Given this list of marker genes NEK3, PRORP, FANCF, STUB1, GSTM4, PFAS, ITPRIPL2, RCC2, FBXO3, ATP6V0E2, RTTN, APIP, ZNF48, SH3GLB1, ALKBH7, ICE2 (NCBI Gene Id 79664), GLOD4, ARMC1, RNF123, NDUFAB1, FUOM, EHF, SOX12, GNB4, TMF1, GLRX5, ZNF569, MLEC, BCL10, NDUFA1, SLC25A26, NET1 (neuroepithelial cell transforming 1), SMC2, FUT11, DCUN1D2, RAMP1, HSCB, IFFO1, RWDD2A, RAD54L, KAT14, RRP36, ARHGAP25, EMC10, AIMP2, PTPA, C19orf44, VPS9D1, THRAP3, ATP13A2, CHID1, DRG2, NDRG3 (NDRG family member 3), TPM2, CD79B, ZNF358, RFNG, ZNF708, IDH3G, ATP8B2, BMAL1, SLC35A4, IPO11, NAGPA, UBR7, ITM2C, GTPBP4, SLF2, NFATC2 (NCBI Gene Id 4773), BCKDK, FCF1, FAM229B, PRR12, LIPA, SULT1A1, ZNF799, RAB3GAP2, TOGARAM1, ANTKMT, CNEP1R1, TBC1D22A, MAP3K1, SLC35B1, TBCCD1, DENND1A, SOCS6, MPHOSPH6, PRIM1, GCN1, MON1A, RTL8C, PRADC1, GUSB, TACC3, GTF3C4, EDEM2, NECAP2, USE1, TBC1D32, SLC5A2, TPK1, DYNLL2, EIF4E, NFS1, LRRC59, DTWD1, CYB561D2, TRIM37, ADGRA2, GPATCH4, CA9, GNPDA2, CRYL1, DPP3, SNX30, COA8, PLCB1, BOD1, OSTM1 (NCBI Gene Id 28962), AP3S2, SMC5, ST6GALNAC6, PBX3, HYCC2, BORA, NPLOC4, FANCM, CALU, CANX, INPPL1, ZNF512B, ZNF516, BBS9, DLGAP4, L2HGDH, POLR2J (NCBI Gene Id 5439), SREBF1, RAB22A, CREB3L2, INO80, NR2C2AP, ARL4A, RHEBL1, PPIL2, EHHADH, NIBAN2, GALK1, MYOF, SEC11A, FOXRED2, WDR45, TERF2, GPR183, EPM2AIP1, RTEL1, ZNF280C, GSTK1, MZB1, TSNAX, IFT22, SSX5, KDM2B, MTFR1L, IFT172, ATRAID, TGM4, VAC14, ETFDH (NCBI Gene Id 2110), RBM28, XAF1, MAP3K20, PCBD2, NUP93, PARK7, NTAQ1, MGST3, HSPE1, AK3, GPATCH1, CHURC1, MRPL35, DFFB, STBD1, TRIM21, DNAJC17, GUF1, POLR2C, MRPL2, AMMECR1L, CTNS, DMAC2, FDX1, MAPK14, PDXP, TRAF3IP1, KCTD2, TEN1, XIAP (X-linked inhibitor of apoptosis), GLCE, here is a description of the gene set: Genes down-regulated in comparison of eosinophils treated with IL25 versus macrophages treated with IL25. Many symptoms associated with allergic asthma result from the sequelae of type 2 inflammation. Interleukin (IL)-25 promotes type 2 inflammatory responses, and T2M cells represent an IL-4 and IL-13 producing granulocytic IL-25 responsive population. We used microarrays to characterize the gene expression profile of T2M cells, and compared T2M cells to other inflammatory subsets (eosinophils, neutrophils, and macrophages) in the lungs of mice with IL-25-induced pulmonary inflammation. Human Gene Set: GSE36392_EOSINOPHIL_VS_MAC_IL25_TREATED_LUNG_DN studied in species Homo sapiens from publication Petersen BC, Budelsky AL, Baptist AP, Schaller MA, Lukacs NW (PMID 22543263)